Given this list of marker genes GPD2, NUFIP1, M6PR, RNF2, SRXN1, RALA, SMARCA5, SEMA7A, ANXA3, GSPT1, KIF2A, PDIA5, STAT3, MMP12, BLCAP, PLK2, BCL2A1, AHNAK, ADSS1, AGO2, SERTAD1, STAT4, WNK1, HSPA9, KRT84, ANXA2, LDLR, TOR1AIP2, ENO2, PLSCR1, IRGM, CARD19, INHBC, TPD52, HNRNPA3, SLIRP, ACP3, TRPC5, NAE1, AP3S1, WSB1, GUCD1, SERPINB9, RO60, CD276, DNAJC21, DNAJA2, BMP8B, BMX, KRAS, HAS1, TRAF1, WAC, TMED7, TUBB6, MAP4K4, ADSS2 (adenylosuccinate synthase 2), AVPR2, CENPC, KTN1, FHDC1, VPS4B, KPNA3, IL18RAP, PTGES3, SRGN, SUGT1 (SGT1 homolog, MIS12 kinetochore complex assembly cochaperone, NCBI Gene Id 10910), TWIST2, KCMF1, TPST2, ZP3, PDK4 (NCBI Gene Id 5166), ATP5MK, PCSK5, ANKRD28, EDEM3, HSD17B11, SLC5A1, MARK3, DNAJB6, MDM2, HOMER3, RNF11, NEK4, DNAAF10, TBCA, GCSH, LITAF, TGIF1, UBE2J2, DNAJB2, PHLDA3, IL12B, MAB21L2, BPNT2, NRAP, THAP12, LPIN2, IFIT2, TIMM8A, IRF4 (NCBI Gene Id 4592), PLCB1, USP14 (NCBI Gene Id 9097), UBL3, HIVEP2, NDFIP2, ONECUT1, DHCR24, SNX9, RGCC, FTL, USP9X, CACUL1, CHRNA1, CNOT4, LARP1, DYNC1I1, ADCY6, SSC4D, H2AZ1, HOXA4 (NCBI Gene Id 3201), RAP1B, EEA1, RPL7L1, ANXA10 (annexin A10), LRRC59, NOS2, RPS15A (ribosomal protein S15a), CASP4, STX3, CCAR1, SCIN, RAD23B, RASD1 (NCBI Gene Id 63428), NAMPT, BLK, ADAM15, LGMN, GNAI3, GOLGA4, CBX2, ANXA11, CCNC, CDIP1, DAB1, RAB10, C6orf62, AGFG1, FTH1, TRAF6, LMNA, RBX1 (NCBI Gene Id 9978), RAB5A, PSMD8, SLC51A, PDPN, HNRNPA2B1, SNX4, PRDX1 (NCBI Gene Id 5052), PTGES (NCBI Gene Id 9536), CD83, SHD, WSB2, STXBP3, RAB7A, ADAM17, B3GNT2, YBX3, LPCAT3, GPCPD1, PPP2R2A, PTGFRN, CACNA1S, TBK1, SLC41A1, CDKN1A (cyclin dependent kinase inhibitor 1A, NCBI Gene Id 1026), UBE2Z, PIK3R1, TENT5C, SLC7A11, AEBP2 (AE binding protein 2), LATS2, GJB2, CFLAR, GLRB, CWC22, PPP6C, FABP5, CHD7 (NCBI Gene Id 780907), UBE2D3, BHMT, ARF4, ENPP2, B3GALT1, HSPE1, IL1RN, CLDN7, ELL2, WDR26, RPP30, here is a description of the gene set: species: Homo sapiens from publication Edwards AD, Chaussabel D, Tomlinson S, Schulz O, Sher A, Reis e Sousa C (PMID 12816982) Genes down-regulated in comparison of ex vivo CD4 dendritic cells (DC) versus cultured CD4 DCs. Human Gene Set: GSE339_EX_VIVO_VS_IN_CULTURE_CD4POS_DC_DN The functional relationships and properties of different sub-types of dendritic cells (DC) remain largely undefined. We used a global gene profiling approach to determine gene expression patterns among murine splenic CD11c high DC subsets in an effort to better characterise these cells.